Given this list of marker genes PTGES, KRT8, BLVRB, TBC1D30, KRT15, WFS1, FASN, SLC7A5, STC2, CYP26B1, ENDOD1, TSKU, TPD52L1, FOS, MAPT, KRT18, ANXA9, KAZN (kazrin, periplakin interacting protein), TMPRSS3, RASGRP1, SLC27A2, KCNK5, FDFT1, ASB13, THSD4, ELF3, CD44, PLAAT3, CA12, CLIC3, AMFR, SLC2A1 (solute carrier family 2 member 1), NADSYN1, ITPK1, CCND1 (NCBI Gene Id 893), SNX24, ELOVL2, MYB, CELSR1, SVIL, ARL3, KRT13, TIAM1, CXCL12, NBL1, NRIP1, CALB2, TGIF2, TMEM164, MSMB, FHL2, SEC14L2, PEX11A, BCL11B, PPIF, PDLIM3, RAB17, ESRP2, KLF10, GJA1, FCMR, ADCY9, OPN3, IGF1R, CELSR2, ALDH3B1, B4GALT1, NAV2, RBBP8, SYNGR1, DEPTOR, INHBB, CANT1, AQP3, MUC1, WWC1, ADD3, RHOD, INPP5F (inositol polyphosphate-5-phosphatase F), ADCY1, AFF1, MYBBP1A, RRP12, MREG, CLDN7, HES1, PMAIP1, CCN5, RAPGEFL1, ELOVL5, TFF1, TFF3, KLK10, ABLIM1, KLF4, ABHD2, XBP1, SH3BP5, MAST4, DYNLT3, CISH, PRSS23, P2RY2, MYC, RPS6KA2, NHERF1 (NCBI Gene Id 9368), AKAP1, MICB, MINDY1, MYOF (myoferlin), AREG, NXT1, SYT12, IL17RB, DLC1, GAB2, SLC24A3, ISG20L2, KDM4B, RETREG1, MYBL1, FRK, TUBB2B, OLFM1, HSPB8, IGFBP4, CHPT1, FLNB, DHCR7, BHLHE40, PDZK1, MPPED2, NPY1R, SOX3 (NCBI Gene Id 8256), TOB1, TGM2, CALCR, GLA, EGR3, SFN, SLC1A4, TJP3, ELF1, SLC7A2, CBFA2T3, BAG1, KCNK15, ABCA3, ZNF185, UGCG, SLC16A1, OVOL2, RARA, NCOR2, LAD1, SULT2B1, IL6ST, SLC22A5, TFAP2C (NCBI Gene Id 7022), MED24, PAPSS2, TIPARP, OLFML3, SLC19A2, FKBP5, SLC39A6, SEMA3B, KRT19, AR, BCL2, GREB1, SCARB1, UNC119, RAB31, FARP1, EEIG1, MED13L, HR, LRIG1, PODXL, SCNN1A, REEP1, PGR, TPBG, SLC26A2, SLC1A1, SYBU, SIAH2, DHRS2, DHRS3, SLC37A1, FKBP4, RHOBTB3, MLPH, RET, FOXC1, TTC39A, ABAT, GFRA1, JAK2, here is a description of the gene set: Genes defining early response to estrogen. species: Homo sapiens Human Gene Set: HALLMARK_ESTROGEN_RESPONSE_EARLY from publication Liberzon A, Birger C, Thorvaldsdóttir H, Ghandi M, Mesirov JP, Tamayo P (PMID 26771021)